Given this list of marker genes DSCC1, CHTF8, RFC2, POLA1, LIG1, RFC1, STN1, ACD, RPA3, WRN, TEN1, RFC3, TINF2 (NCBI Gene Id 26277), FEN1, TERF1 (NCBI Gene Id 7013), POLD2, POT1, POLD3, CHTF18, RPA1, POLD1, BLM, POLD4, POLA2, PCNA, TERF2, PRIM1, PRIM2, RPA2, RFC4, CTC1, DNA2, RFC5, TERF2IP, here is a description of the gene set: Due to the antiparallel nature of DNA, DNA polymerization is unidirectional, and one strand is synthesized discontinuously. This strand is called the lagging strand. Although the polymerase switching on the lagging strand is very similar to that on the leading strand, the processive synthesis on the two strands proceeds quite differently. Short DNA fragments, about 100 bases long, called Okazaki fragments are synthesized on the RNA-DNA primers first. Strand-displacement synthesis occurs, whereby the primer-containing 5'-terminus of the adjacent Okazaki fragment is folded into a single-stranded flap structure. This flap structure is removed by endonucleases, and the adjacent Okazaki fragments are joined by DNA ligase. studied in species Homo sapiens Reactome Pathway: Telomere C-strand (Lagging Strand) Synthesis part of: Extension of Telomeres